Given this list of marker genes TGS1, ZFHX4, RPAP2, TPO, NT5C3A, SKI, ARID2, here is a description of the gene set: Human Gene Set: MIR433_5P from publication Chen Y, Wang X (PMID 31504780) Genes predicted to be targets of miRBase v22 microRNA hsa-miR-433-5p in miRDB v6.0 with MirTarget v4 prediction scores > 80 (high confidence targets). studied in species Homo sapiens